Given this list of marker genes MMP28 (matrix metallopeptidase 28), C5, C5AR2, STK39, CCN3 (cellular communication network factor 3), MSMP, DEFB104B, MIR15A, GPR15LG, HRG, CXCL14, LGMN, DEFB103A, PARVA, CCL7, SLAMF1 (signaling lymphocytic activation molecule family member 1), NCKAP1L, CCL27, S100A8, CXCL3, CCL13, SPI1, CD300H, TNFSF18, ITGB2, PF4, FOLR2, CH25H, NUP85, CALCA, CMKLR1, S100A9, PLEC (plectin), SFTPD, DEFA4, CXCL12, F7, PREX1, BSG (NCBI Gene Id 682), MIR424, S100A14, CCR5, IL23A, SAA1, TREM1, C5AR1, AZU1, EGR3, DEFA1B, FLT1, VEGFA, S100A7, P2RX4, DEFB109B, PPIB, GSTP1, ADGRE2, ACKR2, IL6 (interleukin 6), EDNRB, HGF, CXCR6, CXCR3, PTK2, DEFB114, CSF1R, CD74, TPBG, IL1B, MDK, HMGB2, AKIRIN1, PIK3CD (phosphatidylinositol-4,5-bisphosphate 3-kinase catalytic subunit delta), FGF4, CCL3, EPHB1, MTUS1, TNFSF11, TRPM2, RIN3, RARRES2, CCL20, HSD3B7, ARHGEF16, AGTR1, CCR6, PERP, IL10, TMEM102, CCL22, CCR8, VAV1, PTK2B, KLRC4-KLRK1, GAS6, PLA2G7, IL6R, SWAP70, HSPB1, CCL8, PIKFYVE, PRKCQ, CKLF, GPSM3, PTPRO, CX3CL1, DEFB130A, CXCR2, ANO6, RIPOR2 (RHO family interacting cell polarization regulator 2), CXCL13, CCL18, JAM3, S1PR1, MOSPD2, CCL2, DUSP1, CRKL, CORO1B, SLC8B1, SERPINE1, RPS19, STAP1, EDN1, VEGFB, ABCC1, GAB1, PDE4B, HOXB9, RPL13A, WNK1, CTSG, LYST, TNFSF14, VCAM1, FGF16, PTPRJ, LGALS3, NINJ1, ACKR3, CYP7B1, SRP54, ACKR4, DPP4, DEFB110, CCR10, EPHA2, OXSR1, LEF1, CCL26, C3AR1, DEFB130B, CYP19A1, DPEP1, MIF, CCL17, CXADR (NCBI Gene Id 95792), SMOC2, ARHGEF5, THBS1, FFAR2, XCL2, MIR34A, PF4V1, MAPK1, FGFR1, MAPK3, JAML, XCL1, WNT5A, CXCL16, CCL14, LOX, CCL4L2, SEMA5A, CCL15, FGF1, CCL16, DOCK4, DEFB103B, SLAMF8, DEFB124, RAC1, PADI2, CXCL8, PIP5K1C, DAPK2, KIT, SLIT2 (slit guidance ligand 2), CCL1, CXCR5, NR4A1, SYK, VEGFC, PRKD2, NRP1 (NCBI Gene Id 8829, neuropilin 1), FCER1G, CXCL1, LGALS9, DDT, CSF1, IL12A, GPR183, TIRAP, PDGFB, CXCL6, CXCL10, CNR2, CCR4, CALR, CORO1A, MMP2, LPAR1, CXCL11, CXCR4, NOTCH1, BIN2, DNM1L, BCAR1, DEFA1, CCL5, SBDS, CCL21, MICOS10-NBL1, APP (NCBI Gene Id 351), PDGFD, LYN, MIR16-1, CCR9, ARRB2 (NCBI Gene Id 409), ZNF580, CCR1, DEFB104A, NEDD9, PGF, MET, NBL1, IL17RC, CCL3L3, CCR7, VEGFD, ELMO2, RHOG, PRKD1, ADAM10, ITGA1 (integrin subunit alpha 1), C1QBP, LBP, PLA2G1B, MIR149, PDGFRB, HBEGF, ANXA1, CCRL2, GPR18, PTN, PLXNB3, MSTN, FGF18, IL17RA, MCU, CXCL2, IL16, PLEKHG5, CSF3R, PPBP, CCL11, XCR1, TRPM4 (transient receptor potential cation channel subfamily M member 4), CCL23, RAC2, CXCL5, EDN2, GREM1, MIR223, EDN3, CCL25, CXCL9, THBS4, ADAM17, PPIA, PDGFRA, IL34, CRK, ENG, CCR3, DEFB4A, TMSB4X, CXCR1, FGF2, CCL28, CAMK1D, KLRK1, PRKCD, CHGA, CCL24 (NCBI Gene Id 6369), ALOX5, GBF1, SLC12A2, TNFAIP6, AIF1, CX3CR1, TRPV4, FPR2, VAV3, SCG2, DEFB131A, RAC3, DEFB133, HMGB1, TGFB2, S100A12, CREB3, PIK3CG, TAFA4, TNFRSF11A, RAB13, ITGA9, MPP1, CCL19, F2RL1 (F2R like trypsin receptor 1), CCL4, ADAM8, CXCL17, BST1, CCR2, KDR (NCBI Gene Id 3791), PIP5K1A, here is a description of the gene set: Human Gene Set: GOBP_CELL_CHEMOTAXIS The directed movement of a motile cell guided by a specific chemical concentration gradient. Movement may be towards a higher concentration (positive chemotaxis) or towards a lower concentration (negative chemotaxis). species: Homo sapiens